The following is a description of a gene set: species: Mus musculus Mouse Gene Set: GOCC_PERICENTRIOLAR_MATERIAL A network of small fibers that surrounds the centrioles in cells; contains the microtubule nucleating activity of the centrosome., and this is the list of marker genes: Akap9, Tiam1, Pcm1, Cdk5rap2, Tubg1, Cep85l, Nin (ninein), Cep85, Nedd1, Cep152, Tcp1, Nek1, Rabl2, Bbs4, Cep192, Bbs9, Tubg2, Lck, Pcnt, Dync2i1, Tnks2, Dyrk3, Hook3, Rac1